Given this list of marker genes DHX58, ISCA1, ZBP1, GPR180, IFIT5, TRIM69, CXCL11, JADE2, AIM2, POU3F2 (NCBI Gene Id 5454), NEXN, IRF7 (NCBI Gene Id 3665), SECTM1, SP110, RNF212, STIMATE, TAP1, SLC31A2, XPO6, SAMD9, IFI27L2, TRIM21, CNP, AGAP2, DMXL1, TRIM22, IFIT1, INKA1, CMTR1, HELZ2, GCH1, UBA7, PABIR3, HERC6, ZNFX1, LGALS3BP, USPL1, IRF9, SMAD3, DTX3L, DERL1, SLC25A28, MICB, CCNA2, RUBCN, STAT2, IFI44L, RNF213, ZBBX, IL12RB1, FLJ12825, SEMA4D, BRIP1, TGM1, TNNC1, BRSK1, PIK3R3, TOR1B, SP8, CMPK2, PATL1, CELA2A, FUT4 (fucosyltransferase 4), TRIM5, MORN1, OAS2, IFI6, RTP4, GAREM1, WARS1, RAD9A, XAF1, DDX60, STAT1, PARP14, RNF43, XRN1, MOV10 (Mov10 RNA helicase), ARHGAP27, DAPP1, LINC02579, APOBEC3G, RIPK1, DIPK1B, BET1, STOML1, MYD88, CXCL9, IFIT2, TRIM25, IFI16, RGL1, CD274, COL26A1, GBP1, IL15RA, UGT2B4, ELMO2, ACOT9, GIMAP2, NLRC5, IRF1, TNFSF10, SIGLEC1, SOCS1, EVPL, HS6ST3, HMCN2, PML, SPMIP5 (sperm microtubule inner protein 5), MVB12A, CSRNP1, TAGAP, ANXA2R-AS1, LMO2, KCNQ1DN, RIGI, CXCL10, RSAD2, BATF2, CBR1, H1-9P, SAMD9L (NCBI Gene Id 4827), ATP10A, UBQLNL, RTCB, TENT5A, ZBED1, MASTL, CFAP73, STOM, EPSTI1, UNC93B1, GBP5, STX17, ISG20, TRANK1, AGER (NCBI Gene Id 177), C17orf67, CCL8, ETV7, SWT1, CBLN3, IFI44, USP42, PLSCR1, TRAFD1, HERC5, ISG15, APOL6, PGAP1, MX2, TP53TG5 (TP53 target 5), SHFL, CARINH, USP18, ARSD, TRIM56, ADAR, PARP9, LAP3, FAM8A1 (NCBI Gene Id 51439), CASP8, UBE2Z, APOL1, MFN1, NT5C3A, OAS1, SFT2D2, OASL, OAS3, IFIH1, IFIT3, SNX20, MYH7, ZC3HAV1, KARS1, IKBKE, GTF2B (general transcription factor IIB), CXorf38, PI4K2B (phosphatidylinositol 4-kinase type 2 beta), STARD5, SP100, PHF11, TXNL4B, PARP11, AMOTL2, C1GALT1, PNPT1, ZNF107, EIF2AK2, DDX60L, DYNLT1, MX1, SRGAP2, here is a description of the gene set: Human Gene Set: GSE18791_UNSTIM_VS_NEWCATSLE_VIRUS_DC_6H_DN The dendritic cell (DC) is a master regulator of immune responses. Pathogenic viruses subvert normal immune function in DCs through the expression of immune antagonists. Understanding how these antagonists interact with the host immune system requires knowledge of the underlying genetic regulatory network that operates during an uninhibited antiviral response. In order to isolate and identify this network, we studied DCs infected with Newcastle Disease Virus (NDV), which is able to stimulate innate immunity and DC maturation through activation of RIG-I signaling, but lacks the ability to evade the human interferon response. To analyze this experimental model, we developed a new approach integrating genome-wide expression kinetics and time-dependent promoter analysis. We found that the genetic program underlying the antiviral cell state transition during the first 18-hours post-infection could be explained by a single regulatory network. Gene expression changes were driven by a step-wise multi-factor cascading control mechanism, where the specific transcription factors controlling expression changed over time. Within this network, most individual genes are regulated by multiple factors, indicating robustness against virus-encoded immune evasion genes. In addition to effectively recapitulating current biological knowledge, we predicted, and validated experimentally, antiviral roles for several novel transcription factors. More generally, our results show how a genetic program can be temporally controlled through a single regulatory network to achieve the large-scale genetic reprogramming characteristic of cell state transitions. studied in species Homo sapiens Genes down-regulated in comparison of control conventional dendritic cells (cDC) at 6 h versus cDCs infected with Newcastle disease virus (NDV) at 6 h. from publication Zaslavsky E, Hershberg U, Seto J, Pham AM, Marquez S, Duke JL, Wetmur JG, Tenoever BR, Sealfon SC, Kleinstein SH (PMID 20164420)